Given this list of marker genes PYGB, XPO7, NR2F2, SDC3, SLC4A7, TFE3, SRSF2, PLEKHS1, KIF21B, EI24, ABHD5, CC2D2A, CLOCK, TRMT112, MKRN2, EFNA3, CXCR3, BRPF3, ZIC3, TPTE, DYNLT3, BTRC, TTC21A, MAFG, BNC2, C1QTNF7, LRRTM2, ZBTB4, QKI, CALN1, ZNF385A, IPCEF1, GRAMD1B (NCBI Gene Id 57476), PPP1R18, KCNA1, CD209, HINFP, MAF, SPAG7, UBE2D2, PRKD3 (NCBI Gene Id 23683), HCFC1R1, FKBP5, WAS, CNTNAP3, SCNN1A, MYO1E, GRAP2, ADO, DCAF7, BCAS3, VWA1, TNS1, NEUROG2, ZKSCAN1, SDHC, RAB3A, TMEM131, SYP, SUCNR1 (NCBI Gene Id 56670), MBD6, ADCY9, RALY, PRDM16, ATF7, ZNF703, MFN1, C19orf84, ARPIN, ELK1, MFAP4, HDAC1, CHST3, SERF2, IGFBP4, TMED4, REPS2, ARSI, SAMD4B, GSTM5, PI4KB, CCDC68, USB1, ZMYM3, TAOK3, CANT1, LGR6, INO80D, FKBP1A, LIPT2, NR1I3, RUFY2, FADS2, GIT1, OSBP, PNOC (NCBI Gene Id 5368), VTI1A, CNOT2, LZTS3, CLIC5, SMARCD1, SCAMP5, STEAP3, PRDM11, FRA10AC1, IVL, ITGA7, SH3PXD2A, SHISA6, SCRT2, PHACTR1, TMEM69, TAP2 (transporter 2, ATP binding cassette subfamily B member), SPOCK3, MARCKSL1, DAPL1, DCHS2, ANAPC13, ARFGEF3, ZNF592, CABP5, CSNK1G1, PAMR1, ATXN7L3, WDFY1, KSR2, ZDHHC14 (zinc finger DHHC-type palmitoyltransferase 14), SLC7A14, CD207, CORO2B, RHOC, RAD18 (RAD18 E3 ubiquitin protein ligase), RPL15, P3R3URF-PIK3R3, PIK3R3, FZD2, MXRA5, PDLIM5, ZDHHC3, PAF1, THRA, EP300, BAZ2A, RAB11FIP4 (RAB11 family interacting protein 4), HHLA2, PDYN, MMRN2, FANCC, CNTNAP3B, SEMA4G, YY1AP1, CHRNB2, MARK2, ARID3B, ECE1, RNF14, BRWD1, CNGB1, CPNE5, ZNF346, CXXC4, CERT1, ZBTB20, ATF5, RTN4RL2, LY6D, SPRY4, FYCO1, IFIT1B, NRAS, FOXRED1, CHRNE, CALU, PCDH7, HOXD13, FNBP1L, ELAVL2, TNRC6A, EGR3, TAGLN2, MINPP1, KDM2A, ABCC10, PBX2, UBE2R2, PARS2, KDM4A, PABIR1, LINGO1, OSBPL7, SIPA1L3, ARHGEF7, PCYOX1, TET3, S100A14, CNOT8, AMFR, PTPN14 (NCBI Gene Id 5784), C19orf47, MOXD1, PATL1, NAA40, FCER1G, CD177, NECTIN1, MECP2, CBX4, ASXL3, BRAF, ZCCHC3, GSDMA, SYT7, CCDC178, ZNF516, DDN, PDXK (pyridoxal kinase), NUP205, here is a description of the gene set: Human Gene Set: MIR4271 species: Homo sapiens from publication Chen Y, Wang X (PMID 31504780) Genes predicted to be targets of miRBase v22 microRNA hsa-miR-4271 in miRDB v6.0 with MirTarget v4 prediction scores > 80 (high confidence targets).